The following is a description of a gene set: Human Gene Set: GOBP_CELLULAR_RESPONSE_TO_RADIATION studied in species Homo sapiens Any process that results in a change in state or activity of a cell (in terms of movement, secretion, enzyme production, gene expression, etc.) as a result of an electromagnetic radiation stimulus. Electromagnetic radiation is a propagating wave in space with electric and magnetic components. These components oscillate at right angles to each other and to the direction of propagation., and this is the list of marker genes: GATA3, EEF1D, ITGB6, RGS9, MMP3, CHEK2, BMF, RHNO1, PRKCD, RHOB, PTPRK, EGR1, NMT1, ATF4, SDE2, SMPD1, INO80, IFI16, KDM1A, GRB2, BAK1, GRK4, CRY1, BAX, TMEM161A, USP28, AQP1, BBC3, CERS1, METTL3, SFRP2, RP1, PIK3R1, MFAP4, GUCY2D (guanylate cyclase 2D, retinal), NEDD4, H2AC25, POLK, TREX1, SFRP1, CYBA, OPN1MW2, DDB2, TRPM1, XRCC6, XPA, ZMPSTE24, FBXO4, EI24, CRYAB, TP53, CASP9, TANK, CUL4A, MMP2, RAD9A, COPS9, OPN1MW, PARP1, ERCC4, PCP2, OPN4, ATR, OPN1MW3, CDKN1A, ECT2, BRCA1, TSPYL5, GTF2H5, SNAI2, PARTICL, CREBBP, ST20, TMEM109, PRAP1 (NCBI Gene Id 118471), WRN, MAP3K20, EIF2S1, AKT2, AURKB, OPN3, SPIDR, NFATC4, CUL4B, TGFB1, NLRP1, EIF2AK4, SAG, N4BP1, POLH, CRIP1, NSMCE3, CCND2, MIR21, HYAL2, NMT2, OPN1SW, MC1R, CLOCK, RAD9B, NUCKS1, ELK1, DHX36, BRCC3, RAD1, RPL26, NIPBL, RAD51AP1, BCL2L1 (BCL2 like 1), TNKS1BP1, MMP1, RGR, BABAM2, TRIAP1, MME, INTS7, PBK, MTCH2, RAD51, TLK2, XRCC5 (NCBI Gene Id 7520), NOC2L, KDM4D, GNB5, XPC, RRH, ACTR5, NPM1, AIPL1 (NCBI Gene Id 23746), FBXW7, OPN1LW, GPR88, POLD3, SLC24A2, GRK1, MAPK11, BRCA2, MMP9, LCN2, HSF1, POLD1, HYAL3, YY1, BLM, TNF, ERCC1, BARD1, ZBTB1, FIGNL1, EP300, NET1, GNAT1, CAMKMT, MYC, TAF1, TP53INP1, ATM (ATM serine/threonine kinase), SLC24A4, PIERCE1, PPID, SIRT1 (NCBI Gene Id 23411), RHBDD1, MDM2, CRY2, TP53BP1, STK11, HRAS (HRas proto-oncogene, GTPase), HYAL1, RHO, MAPK13, GRK7, OPN5, GADD45A, PCNA, GPR52, LIG4, YAP1 (Yes1 associated transcriptional regulator), DDB1, GUCY2F, SWI5, TIMP1, RUVBL2, CRB1, HUS1, RBX1, MAPK14, POLA1